Given this list of marker genes SERINC3, LYZ, PELI2, TCF4, PPP2R2B, KAT6A, MIR503HG, FSTL1, KIF20B, EPHB3, FOXP2, RFTN2, GRHL2, TLX3, NFE2L2, ZMYM2, CTNNB1, RBFOX2, FICD, INO80D, CLIP2, CPEB4, LIM2, SATB2, POU3F4 (NCBI Gene Id 5456), PAK1, PHF21A, CHM, STC1, SKIDA1, STAG2, KDM5A, PRICKLE3, NASP, USP25, HTR3B, EIF4EBP2, DUSP5, USP32, CCNJ, CPNE1, TPI1P2, DLG2, FGF9, B3GLCT, TACSTD2, GPC4 (NCBI Gene Id 2239), TNKS2, ZNF668, ZNF646, HOXB5, ZBTB2, MXI1, ARFGEF1, FAM117B, MSI2, RHOB, DLX1, ZNF365, G2E3, NFIA, NTF3, PCSK2, EXOSC2, EML4, HSD11B1, ARMCX6, NCAM1, ZC4H2, RPL23, TNPO3, SPEF1, ZFYVE1, ZNF385B, GLRX5, NIPBL, NR4A1, WNK1, TRERF1, TWIST1, ESRRG, MAF, CASC2, COL4A5 (collagen type IV alpha 5 chain), HHIP, RELT, SLC35B1, COMMD3, ATRNL1, NFIB, CNOT7, PIM1, FOSL2, SESTD1 (NCBI Gene Id 91404), COL4A6, WASL, LMO4, DNAJC17, SEMA3A, TCF12, SPTAN1, DHRS3, PURA, UBR5, LMO3, RERE, G3BP2 (NCBI Gene Id 9908), SALL3, HESX1 (NCBI Gene Id 8820), MAPK3, HOXA2, HOXC4, PAG1, ID1, RBBP4, MAPK14, VSIG1, E2F1, MLLT6, HEPACAM2, NMBR, CAMK1G, INHBA, KLHL13, RALYL, TBL1XR1, POU4F1, MTCL2, KANK1, TUG1, NR2C2, FANCB, SOX5 (SRY-box transcription factor 5), TFDP2, TFAP2B, SEMA6C, HHEX, FST, MARK1, ELAVL2 (ELAV like RNA binding protein 2), MIR137HG, LRCH2, EHBP1, PDZRN4, PRSS12 (NCBI Gene Id 8492), ZBTB18, ANK3, ALDH1A2, MRC2, ARHGAP15, EPHB6, MPPED2, SEMA6A, AUTS2 (activator of transcription and developmental regulator AUTS2), TOB1, FBXO11, DENND4A, DUSP6, FGFR2, OTUB1, BCL11A, ZFYVE19, TP53, EPHB1, SOX6, ANKRD28, H3-3B, DTNA, PUM1, ANGPT1, CSRNP2, SREK1, ISL1, ACVR2A, ZBTB22, PITX1, RARB, CDR2L, EBF1, PPP3R2, MAML3, ATP6V1A, ROGDI, ZIC2, TTC17, ZNF362, TUBB4A, DHX40, FMNL3, PPM1D, NRP1, AMFR, VPS37A, PRPF18, RBM47, ZBED10P, LRRTM3, PLCB1, APBA1, HAPLN2, PPM1B, NFIL3, PTGR3, EN2, MGAT4C, RCN1, HOXA9, ELAVL4, DENND2C, PCDH7, KRT14, HBP1, NANOS1, BNC2, DDX6, YPEL4, KERA, RFX3, RHOV (ras homolog family member V), RHOBTB1, PRDM12, UCK2, ADRB2, RBMXL2, RASSF2, RSPH9, NDNF, MOSPD2, SKAP1, ANK2, PTCH1, EMCN, HS3ST1, MYOT, WRAP53, SOX2, NPTX2, LINC03122, TSC22D3, TRPM6, LRRN1, MYL3, MYLK, C21orf91, FCGBP, SAMTOR, EVA1C, SLITRK2, SPAG9, NECAP1, LINC00649, MORC4, CBFA2T2, RREB1, PREX2, BPTF, NOVA1, TIAL1, ZBTB8OS (zinc finger and BTB domain containing 8 opposite strand), JAM3, KLHL41, SLC13A1, VAV3 (NCBI Gene Id 10451), DEUP1, FAM53B, FOXB1, LDB1, ERBB4, here is a description of the gene set: Genes having at least one occurrence of the motif NNAACAATNN in the regions spanning 4 kb centered on their transcription starting sites. This matches the SOX5 transcription factor binding site V$SOX5_01 (v7.4 TRANSFAC). Human Gene Set: SOX5_01 species: Homo sapiens